The following is a description of a gene set: Human Gene Set: HP_ABNORMALITY_OF_THE_ORBITAL_REGION studied in species Homo sapiens Abnormality of the orbital region, and this is the list of marker genes: ASXL1, TBX3, TBX2, GMNN, USB1, CLCN7, ZBTB24, RHOBTB2, CEP152, TFAP2A, BTNL2, ABCA12, LIMK1, GP1BB, SNRPE, CSNK2A1, SNX14, CRTAP, KATNIP, CTBP1, C2CD3, HCN1 (hyperpolarization activated cyclic nucleotide gated potassium channel 1), CTU2 (cytosolic thiouridylase subunit 2), OTUD5, RAG2, TEFM, SNORD115-1, TALDO1, COPB1, ESAM, SLCO1B1, EPHX2, AHSG, ASPRV1, ALDH6A1, PLOD1, EDNRA, GPC4, DACT1, CRIPT, AP3B1, PAFAH1B1, GTF2I, WARS1, WNT9B, ATP1A2, LZTFL1, WT1, MEGF8, INPPL1, NOP10, ADA, DNMT3B, MAFB, LZTR1, FOXP2, SMPD4, CDK5RAP2, RAD51C, STARD7, GATA4, TNFRSF1A, OSGEP, CENPT, UGDH, BBS1, RPS24, DLX4, FANCL, SMARCD1, PAX1, SLC1A4, GPKOW (NCBI Gene Id 27238), MLPH, TNFRSF1B, SKIC3, WNT4, H3-3A, GNB2, TMCO1, CYP4F22 (cytochrome P450 family 4 subfamily F member 22), SF3B4, CHST3, TARS1, PPM1B (protein phosphatase, Mg2+/Mn2+ dependent 1B), IL7R, XRCC4, MEG3, SOX11, SLC37A4, STEEP1, ATR, SUZ12, GRIA1, HMOX1, PEX6, NOVA2, TYMS, EDN3, ATP2A2 (ATPase sarcoplasmic/endoplasmic reticulum Ca2+ transporting 2), PIGV, VPS51, DYNC2I1, FERMT1, GABRA3, EHMT1, DALRD3, LBR, PLK4, TBX4, ATN1, PLAGL1, VPS37D, CHSY1, GTF2E2, IDH1, FRG1, HYLS1, RAX, RAC3, TRIP12, PGM2L1, SVBP, FRMD4A, NDN, NFIX, MMEL1, BLNK, SERPINH1, RPL35A, TMEM237, CDK10, TRAPPC9, PUM1, PSMC1, FREM2, CIT, MED12, ZNF699, SHPK, MBTPS2, HOXB1, LYN, ZNF462, FANCG, FANCD2, TWIST1, PWAR1, MED12L, KITLG, TONSL (tonsoku like, DNA repair protein), CTNND2, CST6, SMARCA4, RAC1, KNL1, PIK3CA, EBP, ABAT, VARS1, CDSN, GLI3, METTL27, SETD1B, PIGO, FGFRL1, SOX5, PPP2R1A, MSMO1, ABL1 (NCBI Gene Id 25), SALL1, ECM1, PI4KA, PIGU, CDK6, LEMD3 (NCBI Gene Id 23592), NCDN, CLCN1, SMOC1, CHD7, DYM, AKT1, BLM, HS2ST1 (heparan sulfate 2-O-sulfotransferase 1), PAK3, XYLT2, HNRNPC, TNFRSF13B, WDR73, KAT5, AHI1, TNPO3 (NCBI Gene Id 404679), MYMK, CNOT3, COMT, SLCO1B3, IDUA, ASPH, ZNF407, HSPG2, SHANK3, AGO2, GMPPA, CDH2, LTV1, PRKAR1B, PSMC3, SCN8A, MYCN, C4A, SLC26A2, BCL11A, ERCC8, MPDZ, KRAS, DYNC2H1, MANBA, UROD, HIRA, PSMB8, ROR2, PEX19, KRT4, SCNM1, PEX16, GABRD, PGM3, ACTB, COL9A3, ST14 (NCBI Gene Id 6768), SON, SUPT16H, TPRKB, TSC1, TMEM127, TFAP2B, IFT122, YWHAG, POLRMT (NCBI Gene Id 5442), LSS, PRMT7, NUP85, NEXMIF, SCN4A, GDF2, PARK7 (Parkinsonism associated deglycase), KDM1A, GNE, PPP1R15B, PPP1R17, MAPKAPK5, FBLN5, TBC1D24, GNS, TERC, KCNJ2, PTH1R, FRAS1, CERS3, RMRP, SPECC1L, ANTXR1, PWRN1, PHGDH, ATAD3A, ICOS, SEMA5A, XPNPEP2, AIRE, RPL5, INTS1, DRD5, MAP3K7, HHAT, UNC80, CEP41, MYH3, DGCR6, DLK1, RPS23, WDR19, LUZP1, GBA1, CARD14, PPP2R3C, ALDH1A2, RIN2, COL5A1, NDST1, TRAPPC14, HNRNPR, TNFRSF13C, STAT3, NFIB, DPM1, NDUFB11, ACOX1, ZMIZ1, APOE, APC, MTSS2, PCGF2, KMT2A, AP1B1, POU3F3, WASHC5, GNAS, BTD, MVK, DPH5, ERI1, ALX1, TRAIP, DEAF1, MMP23B, TCF20, NCF1, PRKG2, PEX10, KAT6A, BUB1 (NCBI Gene Id 699), GJC2, LIFR, BRCA2, CNKSR2, PCNA, DGCR8, SMARCA2, CSGALNACT1, NUP37, GPT2, ZFX, POLH, ERCC4, LETM1, SRRM2, BAZ1B, CREBBP, HNRNPH2, MESD, RIPK4, PIK3C2A, DVL3, FGF12, VAMP1, SPIB, EDA, TRAPPC11, BRPF1, FRA10AC1, PIGY, GJB6, FAT4, CD151, PEX5, RTL1, TMEM94, U2AF2, ALOX12B, PPP2CA, RPL35, DDHD2, TBK1, TMEM107, TTPA, SV2A (NCBI Gene Id 9900), ZNHIT3, SOX10, DHX16, BCORL1, RHOA, ACER3, C12orf57, HERC1, RBBP8, TOPORS, DNM1, SKI, EXOC8, SIAH1, THOC6, HS6ST2, ALG3, HMGA2, ADNP, SMCHD1, PUF60, BRIP1, HLA-DPA1 (major histocompatibility complex, class II, DP alpha 1), DDB1, CANT1, IFT52, CCBE1, RAP1B (RAP1B, member of RAS oncogene family), BBS7, GREB1L, CNOT2, CYP27A1, FGF20, SUMF1, KDM5B, ZNF526, HLA-B, SDHB, CHUK, AARS1, INTS11 (integrator complex subunit 11), HCCS, BRAF, SLC32A1, SPEN, HDAC4, ERCC2, SOX18 (NCBI Gene Id 54345), FGF10, ORC6, ADAM17, PDHX, PRRX1, ZC4H2, IPO8, TWIST2, GRIP1, PHIP, UBA5, RPS17, FUCA1, AFG2A, FOXG1, ATP7A, XRCC2, BRAT1, SEC31A, UBE2A, ELN, ATM, HSPA9, KRT71, FGD1, IRF6, AUTS2, LPAR6, PARS2 (NCBI Gene Id 91517), DUX4, SETD1A, GTF2IRD1, H1-4, TTC8, TSR2, MCTP2, RPL21, SDHD, ATP6V1B2, TUBB4A, COX7B, SIX5, RECQL4, IFT56, CRKL, CDC45, BUB3, CBY1, SLC25A24, KRT1, FANCF, TMEM138, GATAD2B, PAK2, SMARCC2, PACS2, ALX3, EFTUD2, SLC4A10, DNAJC30, DDX59, IL12A-AS1, GNPTAB, PBX1, KRT86, RLIM, ASPM, MARS1, KMT5B, KANSL1, NGLY1, MDH2, FGFR1, FIBP (NCBI Gene Id 9158), DLST, SF3B2, BCAS3, KDM5A, GPRASP2, GRIN2D, SNAP29, HNRNPH1, MAB21L2, TOR1A, ARL6, MMP2, TERT, PSPH, DSC3, KCNJ5, LMBRD1, CPLX1, ARL3, JAG1, OCA2, FAM20C, WDR37, KIF11, TBL2, ADAMTS10, VHL, OFD1, WASHC4, SOX6, KCNE5, DDB2, IFIH1, TP63, BCOR, MAP1B, DHCR24, TBP, KCNK9, LIG3, LRP2, CTLA4, FTL, HPCA, SGSH, MINPP1, LTBP1, SHMT2, NCAPG2 (non-SMC condensin II complex subunit G2), SPRED2, PTDSS1, ADH5, PKHD1, TBCD, SMO, PHF6, KIF21A, ANO10, UBAP2L, TGM1, RSPRY1, BMP4, RAB23, RAD51, TREX1, ADAR, MYMX, CCDC47 (coiled-coil domain containing 47), CARS1, ERCC6, CCNK, CERT1, SC5D, PEX2, KCNK4, EYA1, MADD (MAP kinase activating death domain), DCLRE1C, PIGN, MECR, SCN9A, TYMP, RPS26, ARID2, WWOX, BCL11B, STRADA, FANCM, NR4A2, WRAP53, DENND5A, POLR3GL, NCAPD3, RASA2, LRP1, PTCH2, FLT4, EXT2, CNTNAP2, BMPR1A, WASF1, MED27, PIK3R2 (phosphoinositide-3-kinase regulatory subunit 2), COL17A1, CLCN3, SMC1A, COL1A2, PGAP3, RAI1, JARID2, HIC1, NANS, MSL3, CAMK2G, JMJD1C, IL12RB1 (NCBI Gene Id 3594), AEBP1, ZPR1, TUBGCP6, TGFB2, PAX2, TRIM44, SARS1, TELO2, FBXO28, B3GLCT, AP1S1, TTC7A, FOCAD (NCBI Gene Id 54914), RALA, PAH, PRIM1, KRT25, CENPE, KIF26A, GLIS3, SCN1A, TSPEAR, PEX14, FOXL2, USP9X, PDCD6IP, KIAA0753, RPS7, IARS2, RPL10, GABBR2, SPI1, TYRP1, FAM111B, FGF3, CHRND, CEP135, EIF5A, CTNND1, GLE1, CYP1B1, CSPP1, PTPN22, ZMPSTE24, RTTN, DYNC2I2, KRT83, BBS10, RNU7-1, PRR12, EDA2R, ALG9, PIGG, AP1G1, MED13L (NCBI Gene Id 23389), CDCA7, EP300 (NCBI Gene Id 2033), DDC, EFEMP1, RAB3GAP2, COL1A1, PIEZO2, PTPN11, MKRN3, FLNB, LRP4, RAP1GDS1, ASH1L, ZSWIM6, SMARCB1, CHRNA1, PREPL, PMM2, GFRA1, HGSNAT, CILK1, PLAA, TMEM53, PPP2R5D, BUD23, UFD1, EDN1, AMER1, CEP55, TFRC, FTSJ1, FAR1, EDAR, ANK1, POU2AF1, PYCR1, EEF1A2, MAN2C1, DPF2, ATRX (NCBI Gene Id 6475), KNSTRN, IGBP1, WDR35, ESCO2, CASP2, TMEM231, THAP1, PIGL, PURA, CHRNG, SCN3A, APC2, BRF1, H4C9, NARS1, TBCK, AKT3, FOXC2, CAMTA1, RPGRIP1L, ZNF148, IFT27, AFF2 (ALF transcription elongation factor 2), TNNI2 (NCBI Gene Id 7136), STAC3, MCPH1, B9D2, ARCN1, SLC1A2, EDEM3, PRKAR1A, CACNA1G, POU4F1, RAD21, SPART, TNRC6B, POLA1, WLS, SRY, CHD1, ANKH, SYNJ1, ARPC1B, EBF3, BUB1B, BBS12, FKBP6, WDPCP, EXOC2, KIT, CACNA1C, NLRP1, WDR62, CLP1, BICRA, ITGA8, ABHD5, MYT1L, PRKCZ, TMEM270, FREM1, TOGARAM1, IFT140, GSC, PDE6D, CD96, CCDC32, CDON, NMNAT1, VPS35L, SCLT1, ACBD6, SPIN4, YARS2, ZNF292, PITX1, TRMT1, IL2RG, LTBP3, NAGLU, GALNT3, PGAP2, SDHC, ADA2, PIEZO1, SLC19A3, COL18A1, IL12A (NCBI Gene Id 3592), UQCC2, MLXIPL, COA3, KCNB1, ATP13A2, DHCR7, SUFU, ABCA5, MBD5, HID1 (NCBI Gene Id 80791), TBX22, H4C5, TCOF1 (treacle ribosome biogenesis factor 1), FANCA, CEP57, TTI2, IFNGR1, SLC2A10, HNRNPU, VPS13B, CHN1, AIP, PLA2G6, ASXL2, GUSB, OGT, GHR, CHAMP1, KIAA0586, TINF2, MUSK, MEIS2, FH, TLR4 (NCBI Gene Id 7099), BMP2, ERLIN2, COPB2, RPS20, FGFR3 (NCBI Gene Id 55546), BBS2 (Bardet-Biedl syndrome 2), PDGFRB, BTK, STX16 (NCBI Gene Id 8675), CDK13, KIF1B, ERCC5, CYFIP2, CACNA1B, DGCR2, ASXL3, TUBB3, PLG, KMT2C, EIF4A2, OBSL1, IL10, IL11RA, SOX9, RPS10, CEP295, ADAT3, PEX1, ATP9A, MAGEL2, TLK2, CACNA1A, ALDOA, ERF, UFC1, ERAP1, PTEN (phosphatase and tensin homolog), TBC1D2B, HNRNPK, PEX11B, AP4E1, RNF2, HLA-DRB1, VPS33A, FLNA, PTPRF, CTCF, RPS19, WNT5A, PIGK, RYR3, CHD8, DDR2, TRPS1, TRAPPC10, DOLK, DSE, CHD6, LPL, NLRP3, TRIM32 (tripartite motif containing 32), STT3A, GPC6, ADAMTS3, COQ4, CNTNAP1, KCTD1, DYRK1A, CDH11, KCNN3, NRAS, SIM1, SASS6, APOA2, SLC30A9, NBAS, ATRIP, AP3B2, PIK3R1, SLC39A7, RUSC2, ITGB4, STIL, RPS28, AGR2, AFG2B, NECTIN1, MAB21L1, ANKRD17 (NCBI Gene Id 84177), AGO1, COL11A2, CD19, MKKS, CLTCL1 (clathrin heavy chain like 1), HOXC13, SLC9A6, ADAMTSL2, FBXO31, TCF3, APCDD1, FIG4, RECQL, KAT8, EXOSC1, LMNA, XPA, ANO3, RALGAPA1, HERC2, DYNC1I2, WDR4, TAF13, H4C3, RNF125, KRT17, HLCS, MEF2C, AAAS, CCND1, DHX9, COLEC11, SPTBN1, PIGQ, KDM6A, UBR1, TGFB3, ZMYND11, OTX2, SEMA3E, RRAS2 (RAS related 2), TAF4, QRICH1, KMT2B, MFSD2A, PACS1 (phosphofurin acidic cluster sorting protein 1), TCTN2 (tectonic family member 2), COG1, TRAF3IP2, SNRPB, SPOP, MTX2, ZMYM2, BBIP1 (NCBI Gene Id 92482), SLC6A9, EED, MED13, NIPBL, PLOD3, TAF6, ZNF711, BIRC3, PRKD1, SIX2, HUWE1, CAMK2A, ZNF423, RBL2, ARHGEF2, DYNC2LI1, ANAPC1, DONSON, RDH11, NSRP1, CTC1, IGSF3, RIT1, STRA6, DLG3, ALG12, CD28, P4HB, RBPJ, THUMPD1, ARX, HBA1, DNASE1L3 (deoxyribonuclease 1L3), IGF1R, BBS4, NEK1, RTEL1, KRT85, MOGS, CBL, NAGA, POLR1B, CELF2, RPS29, NEK9, RPL31, KRT10, LIPN (NCBI Gene Id 648165), RERE (arginine-glutamic acid dipeptide repeats), EZH2, SH3PXD2B, IFT43, GJA5, ARID1B, ITGA6 (integrin subunit alpha 6), DDX3X, NECTIN4 (NCBI Gene Id 91969), UBE3B, CCND2, SETX, BRD4, CEP63, HIVEP2, CEP290, KDM4B, RYR1, COLEC10, AIFM1, UBAC2, KIF15 (NCBI Gene Id 56992), PKP1, MAPK8IP3, GTPBP2, RNASEH2B, PRPS1, BGN, ESS2, TUBGCP2, BCL10, HECW2, NFIA, GSN, PEX26, ZEB2, EPG5 (ectopic P-granules 5 autophagy tethering factor), RPL11 (NCBI Gene Id 6135), ATP6V1A, MTOR, CUL7, MAN1B1, PUS1, CAMKMT, RRAS, HPDL, ARL13B, ADARB1, SET, HELLS, MAN2B1 (mannosidase alpha class 2B member 1), HEATR3, WAC, SEC23B, ETFA, SALL4, STX11, HRURF, NSD2, TRMT10A, NSUN2, ACVRL1, CDK19, SLC45A1, BCR, ABCG8, DSG4 (desmoglein 4), MACF1, EFNB1, SMARCE1, SLF2, ABCA1 (NCBI Gene Id 8371), ZIC2, IFT57 (intraflagellar transport 57), PLEC, COL11A1, VDR, CD79A, RBM10, RRAGC, NF1, SATB2, NF2, CCDC22, GNPNAT1, MN1 (MN1 proto-oncogene, transcriptional regulator), MCM7, SLC9A7, ITGB6, GTF2H5, HGD, CDC42BPB, LMBRD2, PAX3, PANK2, SIX1, KCNH1, COL25A1, COX5A, PIBF1, HLA-DPB1 (NCBI Gene Id 3115), ALX4, GNAQ, HDAC8, EXOSC9, BPTF (NCBI Gene Id 348241), KCNMA1, SOS2, GJA1, NIPAL4, NPM1, TGFBI, KCNA2, SLX4, FAS, DHDDS, UMPS (uridine monophosphate synthetase), UBE3A, DRG1, STX1A, RPL27, GTF2IRD2, SLC29A3, FZR1, TRAF7, BMP1, AFF4, PPP1R12A, NR2F1, RPL26, FGFR2, IKZF1, LAS1L, COL7A1, EFEMP2, KDM6B, IGHM, TIMM50, MECP2, POLR1C, PCSK9, FBXO11, KAT6B, FLCN, KANK2, HMX1, PTCH1, CASZ1, FLI1, SDHA, ACTG1, SPRED1 (sprouty related EVH1 domain containing 1), ANKRD11, QARS1, HBA2, MKS1, NUAK2, FERRY3, SHROOM4, PRDM16, PYCR2, PCDHGC4, PLCD1, CPLANE1, ZIC1, MICU1, COG7, PHF21A, PDPN, ZBTB20, RPL15, IRX5, NOTCH2, ERCC1, HK1, LRRC8A, NPAP1, TMEM67, HECTD4, TRPM3, AXIN2, WNT10A, LIG1, KRT81, DOCK7, MYOC, NAA60, AHDC1, RFX7, YWHAE, SNRPN, TASP1, CDKL5, RAB34 (RAB34, member RAS oncogene family), CC2D2A, SCAF4, GON7, LAMA3, EMC10, ITPR1, AFF3, CACNA2D1, POGZ, TKT, COL3A1, TUBA1A, CWC27, DOCK3, TMEM216, PIGW, PNPLA6, PDE4D, RPL9 (ribosomal protein L9), CP, EXT1, MYL11, NONO, NUP188 (NCBI Gene Id 23511), TOE1, IFT74, KCNC2, TRRAP, MC1R, CHST14, ACSL4, IQSEC2, ALG14, SASH1, SH3BP2, RAB11B, PPP1CB, PIGB, NSDHL, SLC3A1, KRT14, PUS7, CFAP418, METTL5 (methyltransferase 5, N6-adenosine), UBE4B, APOB, SMAD2, UROS, SNORD116-1, ATP6V1E1, ACTL6B, TXNL4A, MAX, DPYSL5, BAP1, DBR1, EIF2AK3, LRPPRC, H4C11, SDHAF2, PALB2, ATP6V0A2, PGAP1, HSD17B4, PAX6, NAA10, SCARF2, KIF14, INPP5E, BMPER, SMAD4, CCR1, KPTN, KIF7, ADAMTS18, ZBTB18, GPC3, POLR1D, RPS15A, RPS27, PHF8, CCDC8, FANCI, DNA2, SEC24D, RAPSN, PLPBP, TENM3, PLXND1, RET, SREBF1, SOS1, PSMB4, SETD2, LONP1, TYR, OTUD7A, EDNRB, XYLT1, LDHD, PARN, CR2, GJA8, PNPLA1, G6PC1, GLI2, SYT1, UGP2, NELFA, PEX7, MAF, TENT5A, LDLR, TNFSF15, PHOX2B, FDFT1, PLXNA1, KLRC4, GABRA2, IL6ST, SLC39A13, SDCCAG8, TUBGCP4, TMEM147, MED25, MYO5A, TBL1XR1, PIGT, ALOXE3, ETFB, HEPHL1, FKBP14, ANKLE2, DPH2, PHC1, EDARADD, GABRA5, NKX6-2, SLC25A11, COG6, TAF1, PRORP, XPC, CDC42, APOA1, FGF5, LIG4, MPLKIP, SAMHD1, MID1, LMX1B, LRBA, SCARB2, TRIO, SATB1, CLTC, SDR9C7, PLCB4, SEPTIN9, DHODH, CUL4B, WNK3, RNASEH2A, HR, VPS13A, GPR101, DMXL2, SMC5, RNF168, FANCB, SMC3 (NCBI Gene Id 9126), COL9A1, RIC1, ADAMTS2, RNU12, DDX11, FILIP1, MITF, GALNT2, PIGS, TRAK1, SLC6A17, PHOX2A, DNMT3A, DOCK6, SRCAP, SLC1A3, FAM149B1, NDUFS4, LMNB1, TCTN1, NEUROG1, NBN, PRDM13, STAG1, DPH1, COL5A2 (collagen type V alpha 2 chain), FOXP1, TEK, SLC35C1, RAB18, KCNJ6, NHP2, FBN1, PPP1R21, GABRG2, KATNB1, SNAI2, HRAS, CEP120, RNF113A, DOK7, RPS6KA3, DDX6, KREMEN1, UHRF1, ANGPT2, ENG, DPP9, PEX3, PIK3CD, LTBP2, CEP104, CHMP1A, TBX15, SLC13A5, SMS, SLC38A3, POLG, YY1, GORAB, KRT74, SETD5, NOD2, MGAT2, LIPH, DIS3L2, KLF13, TTC5, FBXL4 (F-box and leucine rich repeat protein 4), IL23R, FANCE, ZNF469, IGLL1, ETFDH, RREB1, ALG2, WBP4, CHD4, MAPK1, DKC1, SZT2, RFC2, PDE11A, RRM2B, MAPT, NALCN, USF3, TUBB, MAP2K1, IFNG, WIPF1, RPL8, EGFR, PIGA, RNF135, CLDN1, NOTCH3, ITGA3, MTHFS, TMEM218, MAPRE2, SPINK5, GLA, NPHP1, TRIP13, PSMD12, TSC2, FANCC, IL1RAPL1, MEFV, C1GALT1C1, IFT80 (NCBI Gene Id 57560), PKDCC, SLC39A4, DNAJC21, KCNJ8, CASK, EIF4H, CCDC88A, BLTP1, TBR1, B3GAT3, PRTN3, TUBB2B, TAPT1, DVL1, AMPD2, HIBCH, KCTD17, RNASEH2C, TET3, PCNT, OTUD6B, KDF1, MPC1, RB1, CLCN6, SULT2B1 (NCBI Gene Id 6820), BBS9, WNT7A, PPP3CA, PITX2, RNU4ATAC (NCBI Gene Id 57788), DHX30, RNU4-2, NTRK2, BRCA1, NAA80, CUX1, PCLO, ORC1, SEC24C, NXN, WAS (WASP actin nucleation promoting factor), MYOD1, STAT4 (signal transducer and activator of transcription 4), ERCC3, RBMX, LEMD2, NUS1 (NUS1 dehydrodolichyl diphosphate synthase subunit), FOXC1, ATP1A3, DEPDC5, AASS, NSD1, MRPS2, JUP, FZD2, MTTP, KMT2D, KMT2E, ROBO1, UBE2T, HBB, GABRB2, APTX, BBS5, GATA2, CHRNA7, KCNAB2, CCNQ, CCDC28B, GATA1, RAG1, MATR3, SAMD9, DPYD, TGDS, TCTN3, LARP7, LYZ, IRF5, SHOC2, MAP2K2, RFWD3, RAF1, MMP14, ARVCF, OCRL, EXTL3, MAD2L2, WNT10B, TRIM8, SETBP1, YARS1, NRCAM, COG8, CSF1R, GAD1, AMMECR1, B9D1, GJB2, CEP19, TCF4, HYMAI, KLLN, ODC1, ABCC9 (ATP binding cassette subfamily C member 9), ASAH1, DUX4L1, ERMARD, PEX13, CD79B, ARMC9, DSP, ARID1A, TACSTD2, CLCN4, SOX4 (SRY-box transcription factor 4), NECAP1, KIFBP, SIN3A, SCAPER, PQBP1, MRAS, CHD3, STAG2, TFE3, MASP1, CCDC115, NOG, TBX1, WDR26, VPS53, BANF1, SYNGAP1, GRIA3, UBR7, PSAT1, POLR3A, CDH1, EXOSC2, FLII, B4GALT7, FHL1, ALDH1A3, TBX6, GDF11, CLIP2, CKAP2L, CDH3, STXBP1, TGFBR1, NUDT2, DCHS1, NAA20, MRPL12, MSH6, CRELD1, CNOT1, VAC14 (VAC14 component of PIKFYVE complex), ECEL1, DYNC1H1, POLR1A, LSM11, RPL18, IFT172, CWF19L1 (CWF19 like cell cycle control factor 1), REV3L, KDM5C, SLC17A5, PEX12, ASCC3, MALT1, NEPRO, CTSA, CHD5, SLC35A2, EPS8L3